Given this list of marker genes MAPK14 (mitogen-activated protein kinase 14), ADAM17, PLK2, MYH9, FURIN, RHBDF2, IL6, IL10, CD163, here is a description of the gene set: Reactome Pathway: CD163 mediating an anti-inflammatory response studied in species Homo sapiens part of: Anti-inflammatory response favouring Leishmania parasite infection High expression of the membrane protein CD163 in macrophages is a characteristic of tissues responding to inflammation elicited either by an intracellular pathogen infection (such as Mycobacterium leprae or Leishmania spp.) or due to an acute or chronic inflammatory disorder. The soluble form of this molecule, sCD163, is considered to be a potential inflammation biomarker and a therapeutic target; sCD163 is formed from the increased shedding of CD163 mediated by the tumor necrosis factor-α (TNF-α) cleaving enzyme, ADAM17 (Etzerodt & Moestrup 2013, Silva et al. 2017). The biological function of sCD163 is not yet clear, although several possible functions have been proposed: opsonization of Staphylococcus aureus, inhibition of T-cell proliferation and inhibition of tumor necrosis factor-like weak inducer of apoptosis (TWEAK).